The following is a description of a gene set: part of: Developmental Biology Reactome Pathway: MITF-M-regulated melanocyte development Melanocyte Inducing Factor (MITF, also known as Microphthalmia-associated transcription factor) is a key regulator of melanocyte differentiation and development during embryogenesis, of differentiation of melanocyte stem cells post-natally, and of melanoma cells. <br>Melanocytes are cells that possess specialized organelles called melanosomes that synthesize eumelanin and pheomelanin from tyrosine in a series of reactions. Melanosomes are transferred from cutaneous melanocytes to adjacent keratinocytes to provide protection against UV as well as coloration of skin, eye, hair, feathers and scales. Besides being found in the basal layer of the skin, melanocytes are also present in hair follicles, the inner ear and in the iris eye, among other places. The eye also contains a layer of melanosome-containing cells behind the retina, called the retinal pigment epithelium (RPE).<br>Cutaneous melanocytes and their precursors, melanoblasts, arise during embryogenesis from neural crest cells that migrate dorsolaterally through the developing embryo. They also arise from glial/melanoblast precursors migrating on a ventromedial pathway and along nerves. Expression of MITF is a key determinant of melanocyte fate, and mutations in MITF are associated with a variety of defects in pigmentation as well as with deafness (due to absence of melanocytes in the inner ear) and microphthalmia (due to aberrant development of retina and RPE), among other conditions.<br>The gene for MITF encodes several distinct isoforms based on alternative splicing. The gene has a 3' portion consisting of exons 2-9 that are generally shared by all transcripts. In mice and humans, the upstream region of the gene contains 9 exons, some of them coding, some not, and each regulated by its own promoter. Most of them are spliced to exon 2 via a common exon 1B. An exception is exon 1M which is directly spliced to exon 2, giving rise to the so-called M-isoform of MITF. This arrangement gives rise to a number of different mRNA and protein isoforms with preferential expression patterns. Exon 1A-containing transcripts, for instance, are ubiquitously expressed, exon 1H-containing transcripts are highly expressed in the heart, exon 1D-containing transcripts are expressed in the RPE, and exon 1M-containing transcripts are expressed in neural crest-derived melanocytes. Nevertheless, there is little information on whether the different isoforms have different functions except that exon 1B-containing transcripts (but not MITF-M) harbor a sequence subject to mTORC1 regulation. Most if not all transcripts come in two additional splice versions, one including and one excluding 18 bp of part of exon 6, called exon 6A, which encodes 6 amino acids lying upstream of the DNA-binding domain and which is regulated by MAPK signaling. They are usually referred to as the (+) and (-) versions of MITF. While the (-) version of a fragment of MITF-M has slightly reduced DNA-binding affinity compared to the (+) version, no specific role has so far been found for exon 6A. Cell-based assays suggest that MITF (+) has a strong inhibitory effect on cellular proliferation relative to the (-) version, and MITF (-) is expressed at high levels in melanoma cells.<br>This pathway focuses on the activity of the melanocyte lineage-specific transcription factor MITF-M, although some of the biology described may also be relevant for other MITF isoforms. species: Homo sapiens, and this is the list of marker genes: HDAC1, ATP6V1D, ATP6V1C1, USF1, SMARCC2, SOX10, AKT2, CREB1, MCM5, YWHAG, ATP6AP2, DARS1, KARS1, CDKN1A, EP300, MCM2, XPO1, ATP6V0E1, DIAPH1, ARID1A, ARID1B, CDKN2A, ZIC1, SNAI2, TFE3, CDH1, MLANA, ATP6V0E2, DPF1, POU3F2, TFEB, YWHAH, ATP6V1F, TCF7L1, IRF4, KITLG, ATP6V0C, BCL7A, BCL7B, MET, SERPINE1, EPRS1, ITGA2, MYRIP, MITF, PLK1, ATP6V1G1, KIT, SMARCA4, SOX9, CCND1, MC1R, TFEC, RAB27A, LARS1, ATP6V1A, DPF2 (NCBI Gene Id 5977), SMARCD1, MARS1, TCF7L2, RPS6KA1, CCNB1, EDN3, GSK3B, CDK2, CDC25B, BCL2A1, SMARCC1, PMEL, YWHAZ, SMARCE1, SS18, PAX3, POMC, AGO3, TRPM1, SUMO1, MARK3, GXYLT2, ATP6V0D1, ACTB, TNRC6B, FOXD3, ATP6V1H, ASAH1, MOV10, ATP6V0A1, AGO4, ACTL6A, CTNNB1, CREBBP (CREB binding protein), MAPK3, AKT3, PXN, SS18L1, MAPK14, LIG1, WNT3A, CDH2, ATP6V1E1 (ATPase H+ transporting V1 subunit E1), AIMP2, BRCA1, ALX3, PXDN, GMPR, TYR, YWHAB, ATP6V0B, MC5R, ATP6V1B2, DPF3, SMARCD3, EDNRB, MAPK1, GPR143, TBX3, TCF7, HINT1, BCL2, SIRT1, UBE2I, DICER1, EDIL3, YWHAE, ZEB1, DCT, TNFSF11, SYTL2, EEF1E1, SMARCD2, SOX2, PPARGC1A, TYRP1, RARS1, EDN1, AIMP1, MLPH, QARS1, CSF1, SIN3A, MYO5A, SMARCA2, IARS1, BIRC7, TERT, ID1, CEACAM1, MC4R, AGO1, TNRC6C, AGO2, TFAP2A, STT3B, MC3R, BCL7C, LEF1, TNRC6A, MIR211, SMARCB1, TBX2